The following is a description of a gene set: Mouse Gene Set: GOBP_POSITIVE_REGULATION_OF_FIBROBLAST_MIGRATION species: Mus musculus Any process that increases the rate, frequency or extent of fibroblast cell migration. Fibroblast cell migration is accomplished by extension and retraction of a pseudopodium., and this is the list of marker genes: Zfp640, Ager, Akt1, Akap12, Slc8a1, Fgfr1, Ddr2, Pak3, Tfap2a, Uts2 (urotensin 2), Actr3, Acta2, Mmp1a, Dmtn (NCBI Gene Id 13829), Itgb3, Aqp1, Prkce, Pdgfb, Pak1, Itgb1, Apc, Thbs1, Tsc2, Ptk2, Bag4, Tgfb1